The following is a description of a gene set: Reactome Pathway: FGFR1 ligand binding and activation part of: Signaling by FGFR1 The vertebrate fibroblast growth factor receptor 1 (FGFR1) is alternatively spliced generating multiple variants that are differentially expressed during embryo development and in the adult body. The restricted expression patterns of FGFR1 isoforms, together with differential expression and binding of specific ligands, leads to activation of common FGFR1 signal transduction pathways, but may result in distinctively different biological responses as a result of differences in cellular context. FGFR1 isoforms are also present in the nucleus in complex with various fibroblast growth factors where they function to regulate transcription of target genes. <br><br>FGFR is probably activated by NCAM very differently from the way by which it is activated by FGFs, reflecting the different conditions for NCAM-FGFR and FGF-FGFR interactions. The affinity of FGF for FGFR is approximately 10e6 times higher than that of NCAM for FGFR. Moreover, in the brain NCAM is constantly present on the cell surface at a much higher (micromolar) concentration than FGFs, which only appear transiently in the extracellular environment in the nanomolar range. studied in species Homo sapiens, and this is the list of marker genes: FGF8, FGF4, FGF2, FGF22, FGF1, FGF6, ANOS1, FGFR1 (fibroblast growth factor receptor 1), FGF17, TGFBR3, GIPC1, FGF20, FGF9, FGF5, FGF23, FGF3, KL, FGF10